The following is a description of a gene set: Human Gene Set: HP_ABNORMAL_PLACENTAL_MEMBRANE_MORPHOLOGY Structural anomaly of the fetal membranes (also known as the amniochorionic or placental membranes), which comprise a vital intrauterine compartment, where they perform mechanical, immune, and endocrine functions to promote growth of the fetus and protection from environmental adversity. Amniochorionic membranes anatomically consist of a single layer of cuboidal amnion epithelial cells, chorionic trophoblasts, and scattered fibroblasts connected by a layer of type IV collagen-rich extracellular matrix. Abnormal placental membrane morphology species: Homo sapiens, and this is the list of marker genes: TBC1D24, GJB2, FERMT1, ZMPSTE24 (NCBI Gene Id 10269), KANK2, LORICRIN, TRPV3, TP63, GJA1, POMP, GLE1, SMARCAD1, ATP6V1B2, KRT1